The following is a description of a gene set: species: Homo sapiens Small basal ganglia Decreased size of the basal ganglia. Human Gene Set: HP_SMALL_BASAL_GANGLIA, and this is the list of marker genes: NUP54, CYB5R3, CYB5A, SLC19A3, MT-ATP6, ADAR, NANS (N-acetylneuraminate synthase), HIBCH, FDXR, CNTNAP1, TUBB3, TBCK, NUP62, VPS13A